The following is a description of a gene set: Polymorphonuclear leukocytes (PMNs) were obtained from healthy individuals in accordance with protocols approved by the Institutional Review Board for Human Subjects at the University of Minnesota and the National Institute of Allergy and Infectious Diseases. PMNs (107) were combined on ice with live S. aureus (108) or with live or heat-killed A. phagocytophilum (bacteria isolated from 5x106 infected HL60 cells for a ratio of 1 infected HL60 cell: 2 PMNs, ~ 5-20 A. phagocytophilum: PMN) in wells of a 12-well tissue culture plate (pre-coated with 20% autologous normal human serum). Unstimulated control assays received either buffer (for S. aureus comparisons) or clarified HL60 lysate (for A. phagocytophilum comparisons). Plates were centrifuged at 350 x g for 8 min at 4oC to synchronize phagocytosis and incubated at 37 deg. C in a CO2 incubator for the indicated times. At the indicated times, tissue culture medium was aspirated from the plate and PMNs were lysed directly with RLT buffer (Qiagen, Valencia, CA). Purification of PMN RNA and subsequent preparation of labeled cRNA target was performed as described in Methods. Labeling of samples, hybridization of cRNA with HU133A oligonucleotide arrays (Affymetrix, Santa Clara, CA), and scanning were performed according to standard Affymetrix protocols ( http://www.affymetrix.com/pdf/expression_manual.pdf ). Experiments were performed in triplicate, using PMNs from three healthy individuals for each treatment. studied in species Homo sapiens Human Gene Set: GSE2405_0H_VS_6H_A_PHAGOCYTOPHILUM_STIM_NEUTROPHIL_DN from publication Borjesson DL, Kobayashi SD, Whitney AR, Voyich JM, Argue CM, Deleo FR (PMID 15879137) Genes down-regulated in polymorphonuclear leukocytes (6h): control versus infection by A. phagocytophilum., and this is the list of marker genes: COL9A2, TRABD2A, CABCOCO1, GINS1, GABRR1, CSPP1, GAB1, AHI1, CCDC47, DLG1, CNR1, RIPPLY3, ADAMTS16, BHMT, BHMT2, ADH1B, GLRA3, EPB41L2, GNAQ, TMEM255A, CALML6, GGTA1, EVC2, FOXC1, DVL3, DAP3, DNAJC1, C1QTNF2, FKBP4, CRNN, CAMK4, TMA16, CCDC61, GAL3ST3, FOXE1, BPIFA3, ADAMTSL4, CDHR5, CAMK2A, CYP39A1, B3GALT5-AS1, DLEC1, ARMC7, LINC00898 (long intergenic non-protein coding RNA 898), ASIC1, CASS4 (Cas scaffold protein family member 4), ARL13A, C1QTNF8, FAM180B, ABHD17A, FDCSP, DNAJC22 (DnaJ heat shock protein family (Hsp40) member C22), BMF, CFAP45 (cilia and flagella associated protein 45), EBF1, ACOX3, FGR, GNG11, ENOX2, CYP4F3, CLEC2B, CLXN, PRR30, GJB3, BATF2, SDHAF3, ATP5PF, CDC25A, ZFHX3, CCDC178, ACRV1, FUT2, BABAM1, C11orf42, C15orf32, FOXI1, CYP1B1, DEFA6, ATF1, CTSF, CCND3, ALS2CL, DUT, GKAP1, GNAI1, CNGA2, CPXM1, AMER2, CDC14A, CDK4, EYA1, PGGHG, AMZ2, DNAJB2, FOSL1, GMPR2 (guanosine monophosphate reductase 2), AMTN, DHX58, COX7C, DNAJC24, FA2H, AMACR, CDC14C, GABRB3, EPC2, FARP1, CDKN1C, CALHM6, APOL5, CCDC190, FST, CRIM1, COLEC11, FETUB, BAHCC1, CSTL1, ANKRD24, ALG8, CWF19L1, KNOP1 (lysine rich nucleolar protein 1), FAM181A, GEMIN5, CASP7, ANKRD42, CHORDC1, ANP32A, LINC02868, ANGPT4, ARL13B, C1QL4, ADAMTS17, CYP27B1, GHDC, ARMCX1, ELANE, BOD1, CTSO, C9orf40, COL20A1, CBX8, DHRS7B, FEZ2, AMZ2P1, CIAO2A, FRS3, CD200R1, CNN2, CDH1, PSME3IP1, GHR, CXCL11, NELFB, BHLHA9, FECH, MIX23, DMGDH, GIN1, NOCT, MFSD12, DPT, CXCR5, CTCFL, GLRA1, ERGIC1, INSYN2A, APCDD1, MCEMP1, C4BPA (complement component 4 binding protein alpha), SHLD1, ACSS1, CXCL10, COPZ2, G6PC1, FMN2, ALKAL2, ASAP3, CALR3, CFAP184, CENPV, AKAP12, BOLA3, ZFAND4, ATG3, ADA, AMOT, CTSB, DLC1, GLRX5, EFHD1, BICDL1, FAM90A1, C1orf131, FAM89B, ASPRV1, CEP131, FUT5, DIMT1